The following is a description of a gene set: species: Homo sapiens Any process that results in a change in state or activity of a cell (in terms of movement, secretion, enzyme production, gene expression, etc.) as a result of an ATP (adenosine 5'-triphosphate) stimulus. Human Gene Set: GOBP_CELLULAR_RESPONSE_TO_ATP, and this is the list of marker genes: HSP90B1, P2RY12 (NCBI Gene Id 65213), TAF1, TRPM4, TOP2B, SOD1, P2RY11, P2RY1, TRPV1 (NCBI Gene Id 7442), CIB2, SSH1, P2RY2, RYR3, P2RY4, P2RX7, P2RX3, P2RX4, PDXP, ABCC9